Given this list of marker genes PBX1, CYP19A1, PRLR, PSAPL1, FRS2, ID4, FOXA1, EPHB2, NKX3-1, TP63 (NCBI Gene Id 8860), NOG, OSR2, FKBP4, HOXA9, AMH, RARG, BMP7, SRD5A1, HOXA11 (NCBI Gene Id 3207), HOXA13, SERPINB5, GLI1, PTCH1, FGFR2, PAX8, PLAG1, FGF10, LHX1, PSAP, CYP7B1, SHH, STAT5A, EPHB3, GATA2, SMARCC1, STK11, WNT5A, SERPINF1, ACD, ALOX15B, AR, MMP2, SOX9, CDKN1B, WDR77, UBE3A, HOXA10, RARA, CTNNB1, AHI1, SFRP1 (secreted frizzled related protein 1), CRIP1, ESR1, HELLS, SULF1, IGF1, OSR1, TNC, WNT11, NOTCH1, FEM1B, HOXB13, FOXB1, CRKL, EAF2, PAX2, BMP4, HOXD13, here is a description of the gene set: studied in species Homo sapiens The process whose specific outcome is the progression of the urogenital system over time, from its formation to the mature structure. Human Gene Set: GOBP_UROGENITAL_SYSTEM_DEVELOPMENT